The following is a description of a gene set: Mouse Gene Set: GOBP_RESPONSE_TO_IMMOBILIZATION_STRESS Any process that results in a change in state or activity of a cell or an organism (in terms of movement, secretion, enzyme production, gene expression, etc.) as a result of being rendered immobile. studied in species Mus musculus, and this is the list of marker genes: Reg1, Atp1a3 (NCBI Gene Id 232975), Agtr1b, Sod2, Tph1, Ppp1r9b, Nr0b1, Foxo3, Gltp, Ptk2b, Hnmt, Myrf, Cyp1a1, Crhbp, Ucn3, Hdac6, Mdm2, Ercc1, Gpi1, Ren1, Foxo4, Tgfb1, Fos, Ucn, Aoc3, Pitx3, Lrp11, Cers2, Th, Brd1, Crh, Ptpn5, Ugt8a, Penk, Phb1